Given this list of marker genes NPC1L1, here is a description of the gene set: Reactome Pathway: Intestinal lipid absorption Niemann-Pick C1 Like 1 (NPC1L1) protein in enterocytes is critical for intestinal cholesterol and phytosterol absorption, and is the target of the drug ezetimibe. part of: Intestinal absorption studied in species Homo sapiens